The following is a description of a gene set: An anomaly of the labia, the externally visible portions of the vulva. studied in species Homo sapiens Abnormal labia morphology Human Gene Set: HP_ABNORMAL_LABIA_MORPHOLOGY, and this is the list of marker genes: SETBP1, NIPBL, ORC4, SNORD115-1, KAT6B, SMARCA2, NPAP1, TP63, BRD4, INSR, LIPE, POR, HSD3B2, ESCO2, GMNN, RAB3GAP1, ZFPM2, HERC2, SRY, RAD21, DVL1, RAB18, CTCF, SOX9, PWRN1, PPP2R3C, NR5A1 (nuclear receptor subfamily 5 group A member 1), HYMAI, AR, ACTB, UBE3B, SMC3, VAC14, SLC25A24, PWAR1, WNT5A, SMC1A, GAD1, MAP3K1, SEMA3E, FZD2, PMM2, CHD7, ORC6, VAMP7, ECEL1 (NCBI Gene Id 94923), ESR2, MKRN3, HDAC8, SNORD116-1, MAGEL2, FIG4, WWOX, BSCL2, TBC1D20, CDC45, PLAGL1, SMCHD1, SIM1, CCNQ, ORC1, LMNA, ATIC, OCA2, MYH3, AGPAT2, DHX37, NR0B1, RIPK4, DVL3, TWIST2, GATA4, CDC6, CDT1, MAB21L1, NDN, IRF6, WT1, FGFR2, TAF6, RAB3GAP2, B3GLCT, PORCN, HNRNPR, ROR2, CHRNG, SNRPN (small nuclear ribonucleoprotein polypeptide N)